Given this list of marker genes Rpa1, Mcm7, Orc1, Cdc7, Orc3, Rpa3, Rpa2, Cdc25c, Atrip, Rfc2, Rfc4, Mcm5 (NCBI Gene Id 194478), Mcm3, Cdc45, Orc2, Hus1, Rfc3, Orc5, Mcm10, Cdc25a, Rfc5, Rad9b (NCBI Gene Id 320366), Orc4, Rad17, Mcm6, Mcm4, Mcm8, Clspn (claspin), Rad1, Rad9a, Chek1, Orc6, Mcm2, Cdc6, Dbf4, Cdk2, here is a description of the gene set: studied in species Mus musculus Mouse Gene Set: REACTOME_ACTIVATION_OF_ATR_IN_RESPONSE_TO_REPLICATION_STRESS Activation of ATR in response to replication stress